The following is a description of a gene set: studied in species Homo sapiens Human Gene Set: GOCC_NUCLEAR_CYCLIN_DEPENDENT_PROTEIN_KINASE_HOLOENZYME_COMPLEX Cyclin-dependent protein kinase (CDK) complex found in the nucleus., and this is the list of marker genes: RB1, CDK19, CDK13 (NCBI Gene Id 8621), MED13, SNW1, CDK12, GTF2H2C_2, CCNH, MMS19, CCNC, GTF2H2, CDK7, CCNT1, GTF2H5, ERCC2, BCCIP, GTF2H2C, MED12, GTF2H4, CDK8, CDK9, CCNT2, ERCC3, GTF2H1, CCNK, MNAT1, GTF2H3